Given this list of marker genes IL1RL2, IL6, IL23A, POLR1G, IL37, GATA3, MERTK, POLR1A, PSD4, IL36RN, POLR2E, POLR1C, SOCS3, TMEM87B, IL36B, IL1A, POLR1F, IL36G, IL1R1, TULP1, MIR4435-2HG, SLC20A1, ACOXL, LGALS3, RAC1, CXCL13, CSF2 (colony stimulating factor 2), POLR1D, STAT1, POLR2K, TTL, IL1RN, POLR1H, CSF1, IL36A, POLR2H, POLR2L, IL1RAP, IL2, POLR1B, IL1B, POLR1E, IL1F10, MIR4771-2, ARL14, SOCS1, RGPD8, ZC3H8, MIR4435-2, PLCG2, MAPK1, GRB2, ZC3H6 (NCBI Gene Id 376940), POLR2F, ARF6, CHCHD5, ANAPC1, CKAP2L, GAS6 (NCBI Gene Id 2621), PTK2, NT5DC4, BCL2L11, FBLN7, here is a description of the gene set: 2q13 copy number variation syndrome species: Homo sapiens Human Gene Set: WP_2Q13_COPY_NUMBER_VARIATION_SYNDROME